Given this list of marker genes Vav1, Pak1, Ighv6-7, Ighv7-2, Myh2, Pik3cb, Fyn, Ighv6-6, Ighv5-17 (NCBI Gene Id 780794), Myo10, Igkv2-137, Elmo2, Dock1, Iglc2, Arpc3, Fcgr4, Fcgr2b, Ighv5-2, Arpc1a, Ighv13-2, Pik3r2, Mapk3, Ighv3-3, Src, Myo5a, Igkv17-121, Myo9b, Limk1 (LIM domain kinase 1), Nckipsd, Arpc4 (NCBI Gene Id 68089), Abl1, Prkcd, Hsp90ab1, Igkv11-125, Hsp90aa1, Vav2, Igkv15-103, Ighv7-3 (immunoglobulin heavy variable 7-3), Pla2g6, Igkv20-101-2, Plpp4 (phospholipid phosphatase 4), Wasf1, Hck, Igkv1-135, Ighg1, Igkv1-88, Ighv12-3, Myh9, Igkv1-133, Lyn, Ighv8-11, Ighv5-6, Plcg1 (phospholipase C, gamma 1), Iglc1, Ighv5-4, Crk, Ighv5-9-1, Ighv8-4 (NCBI Gene Id 629919), Igkv1-132, Ighv6-3, Arpc5, Igkv2-109 (NCBI Gene Id 636078, immunoglobulin kappa variable 2-109), Ighv3-8, Pld4, Abi2, Igkv2-112, Ighv8-9, Igkv8-21, Pld2, Ighg2c, Cd3g, Btk, Ighv5-12-4, Igkv1-99, Igkv1-131, Nck1, Brk1, Ighv3-1, Igkv16-104, Actg1, Igkv1-110, Pld3, Igkv1-117, Pik3ca, Igkv18-36, Syk, Ighv8-12, Actr2, Fcgr1, Cdc42, Elmo1, Mapk1, Ighv5-16, Plcg2, Ighv8-8, Igkv1-35 (NCBI Gene Id 637047), Cyfip1, Arpc2, Actr3, Ighv5-9, Ighv6-5, Plpp5, Ighv3-5, Ighv7-4, Myo1c, Ighv3-6, Nf2, Ighv16-1, Grb2, Ighv8-6, Wasf3, Ighv6-4, Ighv3-4, Arpc1b, Ighv8-5, Wasf2, Nckap1, Fgr, Pik3r1 (NCBI Gene Id 328326), Baiap2, Yes1, Nckap1l, Cyfip2, Cd247, Ighv5-12, Ighv5-15, Wipf3, Igkv1-122, Rac1, Igll1, Wipf1, Abi1, Prkce, Ptk2, Actb, Ighv8-2, Ighg3, Vav3, Ighv8-13, here is a description of the gene set: Mouse Gene Set: REACTOME_FCGAMMA_RECEPTOR_FCGR_DEPENDENT_PHAGOCYTOSIS species: Mus musculus Fcgamma receptor (FCGR) dependent phagocytosis